The following is a description of a gene set: Mouse Gene Set: GOCC_COLLAGEN_TYPE_XI_TRIMER species: Mus musculus A collagen heterotrimer containing type XI alpha chains in alpha1(XI)alpha2(XI)alpha3(XI) trimers; type XI collagen triple helices associate to form fibrils., and this is the list of marker genes: Col2a1, Col11a2, Col28a1, Col5a2, Col5a1, Col11a1